The following is a description of a gene set: studied in species Homo sapiens Sclerosis of skull base Increased bone density of the skull base without significant changes in bony contour. Human Gene Set: HP_SCLEROSIS_OF_SKULL_BASE, and this is the list of marker genes: SIK3, MEG3, MAP3K7, TNFRSF11A, ANKH, DLK1, PTDSS1 (NCBI Gene Id 9791), TGFB1, SETBP1, AMER1, FLNA, LBR, RTL1, ACP5, TMEM53, NOTCH3